Given this list of marker genes CD3E, RMND1, KIF3C, C1D, NCOA1, MTARC2, SP3, DNAJA1, ITGAV, LUC7L3, B4GALNT1, MRPL27, MFSD14A, GNPTG (N-acetylglucosamine-1-phosphate transferase subunit gamma), SPICE1, RAD52, PTPN2, IRF7, SEPTIN7, TXNDC12, SEC23A, CAMK2D, MYT1, MTHFR (methylenetetrahydrofolate reductase), TBPL1, SGPP1 (sphingosine-1-phosphate phosphatase 1), DNAJB13, PROP1, DTD2, DMRTB1, CDV3, UBALD2, LEPROT, ROCK1, HNRNPC, MEF2D, SLC25A28, SCN1A, TPRG1L, COPE, CBFA2T3, RBFOX2, LGALS9B, HSD17B11, ACLY, COQ10A, PMPCB, CRISP3, CPSF7, NAB1, NCOA2, TPT1, VAPA, ZDHHC9, FABP9, GPSM3, PTPN5, GNPNAT1, REG3G, RGS19, HAND2 (NCBI Gene Id 9464), BCL10, CACNA1H, ATG13, B3GAT3, MAT2B, IER3, MATN3, CDON, PHKG1, CLGN (calmegin), GNB1, SMAP1, PRXL2A, IMPA1, ECE1, CALCB, TTF1, LGALSL, PGM1, SS18, CCDC28B, MRPL9, SAP30L, LGI4, CENPA, RUNDC3A, RP9, GABRB1, SPAST, CRP, LDAF1, SLU7, PRUNE1, LCAT, TIRAP, CMTM3, SCP2, CHPT1, DDX24, IKBKB, THOC7, IRS2, TNFAIP8L1, VMP1, CCDC6, ANLN, PRMT3, ATXN2, POLR1H, GAA (alpha glucosidase), METTL17, RNF34, S100PBP, YJU2B, RASGRP2 (NCBI Gene Id 10235), TENM1, SPIN1, CAPZA2, PNKP, ADORA2A, GPM6B, ZSCAN26, EMP3 (epithelial membrane protein 3 (MAM blood group)), STX2, EIF2B4, GALK2, HMGB2 (high mobility group box 2), ATP6AP1, MIF4GD, CTNNA2, SMARCB1, SEPHS2, CDKN2D, RER1, LRP6, FRAT2, RAB4A, IREB2, RIPOR2, ATP5PF, DNAJC9, SEC11A, DIAPH1, SPN, RNF181, STK10, C6orf62, MXI1, DDX52, TDRP, CBR1, S1PR1, DPT, CYP4A22, APBB1IP, CUEDC2, PLAC9, ASAH1, ATF2, UBA7, ARF5, CNN2, TCEA1, EGLN2, FLT3, SENP6, UIMC1, ANKRD10, IQGAP2, KAT7, WWP2, MSH3 (mutS homolog 3), CSTF2, ADAMDEC1, NFE2, CLN3, NLRX1, GNA14, ANKZF1, IRAG1, MPHOSPH10, ECPAS, ABRACL, TMEM230, SON, BAZ2A, MPHOSPH9, SLC35A2 (solute carrier family 35 member A2), GLMP, UBE2A, CYB5B, NAA11, WDR82, CDKN1B, BARX1, IVNS1ABP, FBXO38, PREB, CREBBP, here is a description of the gene set: Genes up-regulated in comparison of unstimulated CD8 T cells at 72 h versus CD8 T cells at 72 h after treatment with trichostatin A (TSA). Differentiation of naive CD8 T cells into cytotoxic effector cells requires three distinct signals- antigen (signal 1), costimulation -B7-1 (signal 2) and cytokine, either interleukin-12 or interferon-a/b (signal 3). Interaction of naive CD8 T cells with antigen and B7-1 programs cell division and proliferation whereas the presence of cytokines- IL-12 or IFNa/b promote survival, differentiation and memory establishment. In the absence of signal 3, the cells interacting with antigen/B7-1 undergo tolerance induction. The objective of this study was to elucidate the mechanisms how the provision of signal 3 promotes differentiation and averts tolerance induction in CD8 T cells. Trichostatin A is a pharmacological agent that inhibits histone deacetylase activity, hence regulating chromatin structure and gene expression and differentiation in many cell types. Gene signature profiles of IL-12, IFNa/b and trichostatin A stimulated cells were compared to elucidate the molecular mechanisms of gene regulation. Oligonucleotide microarray analysis is carried out to determine the extent and molecular nature of the CD8 T cell differentiation program induced by IL-12 or IFNa/b in concert with antigen and B7-1 signal. species: Homo sapiens from publication Agarwal P, Raghavan A, Nandiwada SL, Curtsinger JM, Bohjanen PR, Mueller DL, Mescher MF (PMID 19592655) Human Gene Set: GSE15930_STIM_VS_STIM_AND_TRICHOSTATINA_72H_CD8_T_CELL_UP